The following is a description of a gene set: The transformation of benign lesions to malignant tumours is a crucial aspect of understanding chondrosarcomas, which are malignant cartilage tumours that could develop from benign chondroid lesions. However, the process of malignant transformation for chondroid lesions remains poorly understood, and no reliable markers are available to aid clinical decision-making. To address this issue, we conducted a study analysing 11 primary cartilage tumours and controls using single-cell RNA sequencing. By creating a single-cell atlas, we were able to identify the role of endoplasmic reticulum (ER) stress in the malignant transformation of conventional central chondrosarcomas (CCCS). Our research revealed that lower levels of ER stress promote chondrosarcoma growth in a patient-derived xenograft mouse model, while intensive ER stress reduces primary chondrosarcoma cell viability. Furthermore, we discovered that the NF-?B pathway alleviates ER stress-induced apoptosis during chondrosarcoma progression. Our single-cell signatures and large public data support the use of key ER stress regulators, such as DNA Damage Inducible Transcript 3 (DDIT3; also known as CHOP), as malignant markers for overall patient survival. Ultimately, our study highlights the significant role that ER stress plays in the malignant transformation of cartilaginous tumours and provides a valuable resource for future diagnostic markers and therapeutic strategies. Human Gene Set: SU_HO_FOETAL_FEMUR_C4_FIBROBLAST Fibroblast-like cell cluster identified in the human foetal femur sample by the expression of markers COLIAI, VCAN, and VCAMI. from publication Su Z, Ho JWK, Yau RCH, Lam YL, Shek TWH, Yeung MCF, Chen H, Oreffo ROC, Cheah KSE, Cheung KSC (PMID 38267611) studied in species Homo sapiens, and this is the list of marker genes: HMGXB3, MXRA8, ESYT2, RGS2, EMILIN1, DYNC2H1, ANKRD10, COL5A3, ARHGEF12, TNFSF11, KLF10, GNG12, ZNF532, RBMS1, PLS3, IAH1, VCAN, ITGB5, TNC, ANGPTL1, MXRA5, KLF12, SPARCL1, RUNX1T1, C1orf198, TCIRG1, OLFML2B, PRSS23 (serine protease 23), SELENOP, CLMP, CHD4 (NCBI Gene Id 1108), CTSK, CAST, RFTN1, STX7, TAGLN, CYP1B1, HDAC9, HOPX, PARD6G, RIPOR1, SLC3A2, SULF1, ZSWIM8, GGT5, VGLL3, DKK3, KLHL24, EDNRA, TWIST1, DDX5, MAP4K4, DLX5, FGD6, LAMTOR4, COX6B1, BBLN, CALD1, WDFY2, FOXP1, FOXP2, NET1, YWHAZ, SMOC1, JMJD1C (NCBI Gene Id 9323), KCNMB4 (NCBI Gene Id 27345), RPL13A, THADA, SLIT2, RAB3IL1, ECM2, CHCHD10, MAP1LC3A, RIN2, VPS28, BMP4, AFAP1, CYTOR, COL1A1 (collagen type I alpha 1 chain), TP53I3, AXL (NCBI Gene Id 558), LPP, ADGRA2, FLRT2, EFNB1, HTRA1, NAT14, FNDC1, LAMA4, SPRED1, PDLIM5, LTBR, AP2S1 (adaptor related protein complex 2 subunit sigma 1), B4GALT1, DCTN1, BICC1, PLXNB2, SERPINF1, FMNL3, TSPAN11, RUNX1, DYRK2, CD81, ANGPT2, ITSN1, TLN1, PSME1, ARID5B, ITGB1, FAP, S100A4, LEF1, ARL4C, KANK2, SMOX, INF2, RAB11B, PIK3R1, CD248, ANGPT1, MAFB, ETHE1, ABI1, FBN1, MMP9, COL1A2 (collagen type I alpha 2 chain), FOXC1, MMP11, PRRX1, ODF2L, DDIT3, OLFML3, CSF1 (NCBI Gene Id 1435), CAP1 (cyclase associated actin cytoskeleton regulatory protein 1), ANTXR1, MGST3, IFITM1, COL6A3 (NCBI Gene Id 1293), MME, BASP1 (brain abundant membrane attached signal protein 1), TMEM50A, STK17B, DNAJC13, RABGAP1, COL5A1, COL6A1, NOTCH3, VMP1, CEMIP, SCARA3, CNKSR3, FRMD6, COL6A2, SHISA5, RAB31, PCDH18, ZYX, THBS2, ZEB2, OLFML2A, FAT1, PCOLCE, TGFB1I1, MYOF, POSTN, C1R (complement C1r), LOXL1, ANO6, ITGAV, NCALD (neurocalcin delta), COL12A1, HACD4, EPB41L2, RARA, CDH11, DLC1, OGN, SPATS2L, CNN2, KCTD15, AEBP1 (NCBI Gene Id 165), TNFSF12, MMP14, SERPING1, NNMT, KAT7, PRR5, EMP2, MYL12B, HECA, SMCO4, PLAAT4, GPM6B, TGFBI, ENPP2, STEAP4, ANKRD50, SHFL, LTBP4, SOX4, NTAN1 (N-terminal asparagine amidase), MED13, CDH2, TNFRSF1A, COL24A1 (NCBI Gene Id 255631), THY1, TGFB3, PARD3, LSP1, MEOX2 (NCBI Gene Id 4223), MMP13, EVA1B, ARHGAP42, MEGF10, PLEC, RBMS3, IL1R1, MYO1E, RCBTB2, PTPN13, C1QTNF6, FRMD4A, GADD45A, VCAM1